Given this list of marker genes DNAJB13, IGSF3 (NCBI Gene Id 3321), ADA2, DRC1, TRIM37, PNP, IKBKG, SASH3, SLC9A3, PIK3CD, TNFRSF13C, PGM3, MGP, COL5A1, RNU4-2, WIPF1, RAC2, IRF1, ZMYND10, ICOSLG, PTEN, DNAAF5, DNAJC21 (DnaJ heat shock protein family (Hsp40) member C21), COL11A1, RSPH1, CD19, DNAH5, ALX3, IL21R (interleukin 21 receptor), NFKB1, ADA, PTPN22, WAS, RUNX2, RFXAP, NF1, TTC12, SEC61A1, MAGT1, CYBA, NCF1, RFXANK, TNFRSF9 (TNF receptor superfamily member 9), IKBKB, MCIDAS, ATRX, TGFB1, KCNN4, SLC39A7, DNAH11, CFI, HFE, PRKAR1A, USB1, FUCA1, AMER1, UNC119, NEK10, LRBA, CFAP221, DOCK8, PRTN3, SH3KBP1, FMR1 (fragile X messenger ribonucleoprotein 1), CFTR, NCF4, SMCHD1, SPAG1, DNAAF1, C4B, FOXN1, DNAI1, PRKCD, TNFRSF13B, CEACAM3, MDM4, STX1A, BTK, AGA, FLNA, DNAH1, RSPH4A, RFX5, TCF3, COL5A2, RNF168, LIG4, BLNK, SIX2, SPEF2, ZNF341, MPDU1, ALMS1, CCDC40, CFAP300, DNAAF11, HYDIN, CD79B, CFAP52, DNAL1, DNAAF6, NFKBIA (NCBI Gene Id 4792), NCF2, SLC11A1 (NCBI Gene Id 6556), GSTM3, SLC26A9, IGKC, CTSK, TAP2, GCLC, ACP5, CXCR4, CFAP74, DNMT3B, CYBC1, DNAAF4, CEACAM6, GAS2L2, PDE11A (NCBI Gene Id 50940), NBN, IGHM, EDNRA, IRF8, SFRP4, PIK3R1, DNAAF2, CCNO, ELANE, DNAI2, AIRE, RPGR, CIITA, CYBB, DNAH9, MIF, IGLL1 (immunoglobulin lambda like polypeptide 1), ODAD4, ODAD3, FCGR3A, SBDS, STXBP2, NOTCH2, IVNS1ABP, DNAAF3, ICOS, CFAP45, NME8, HLA-DPB1, SPI1, NME5, STK4, CD79A, CCDC39, IL2RG, DCTN4 (dynactin subunit 4), IL17RA, MAN2B1 (NCBI Gene Id 4125), ODAD1, TAP1, SLC6A14, LRRC56, CTLA4, CFAP298, EFL1, CCDC103, CCDC65, ATM, BRWD1, STK36, IRF2BP2, TMCO1, SERPINA1, FOXJ1, CR2, NFKB2, CLXN, CSPP1, OFD1, DNAH7, KCNJ2, TBX1, FCGR2A, HLA-DPA1, PSMB8, RSPH9, TBK1, CLCA4, IGHG2, PSMB4, LRRC8A, RSPH3, ALX1, ODAD2, HMOX1, here is a description of the gene set: Abnormality of the paranasal (cranial) sinuses, which are air-filled spaces that are located within the bones of the skull and face and communicate with the nasal cavity. They comprise the maxillary sinuses, the frontal sinuses, the ethmoid sinuses, and the sphenoid sinuses. Abnormal paranasal sinus morphology species: Homo sapiens Human Gene Set: HP_ABNORMAL_PARANASAL_SINUS_MORPHOLOGY